Given this list of marker genes P4HA1, P4HB, EGLN1, P4HA2, OGFOD1, EGLN2, P3H3, P3H1, P4HTM, EGLN3, P3H2, P4HA3, here is a description of the gene set: Human Gene Set: GOMF_PEPTIDYL_PROLINE_DIOXYGENASE_ACTIVITY species: Homo sapiens Catalysis of the reaction: peptidyl L-proline + 2-oxoglutarate + O2 = peptidyl hydroxy-L-proline + succinate + CO2.